The following is a description of a gene set: species: Mus musculus Mouse Gene Set: GOBP_POSITIVE_REGULATION_OF_EARLY_ENDOSOME_TO_LATE_ENDOSOME_TRANSPORT Any process that activates or increases the frequency, rate or extent of early endosome to late endosome transport., and this is the list of marker genes: Msn, Mtmr2, Vps11, Ptpn23, Rab21, Rdx, Nf2, Dab2, Ezr